The following is a description of a gene set: part of: Death Receptor Signaling Reactome Pathway: FasL/ CD95L signaling species: Mus musculus electronically inferred by orthology from the curated human pathway This event has been computationally inferred from an event that has been demonstrated in another species.<p>The inference is based on the homology mapping from PANTHER. Briefly, reactions for which all involved PhysicalEntities (in input, output and catalyst) have a mapped orthologue/paralogue (for complexes at least 75% of components must have a mapping) are inferred to the other species., and this is the list of marker genes: Fas, Casp8, Fadd, Fasl